The following is a description of a gene set: studied in species Mus musculus Mouse Gene Set: GOBP_POSITIVE_REGULATION_OF_GRANULOCYTE_DIFFERENTIATION Any process that activates or increases the frequency, rate or extent of granulocyte differentiation., and this is the list of marker genes: Lef1, Il5, Tesc, Mir223 (NCBI Gene Id 723814), Ikzf1 (NCBI Gene Id 319751), Tescl, Hcls1, Evi2, Runx1, Hax1, Gfi1b, Evi2b, Trib1